The following is a description of a gene set: Mouse Gene Set: TABULA_MURIS_SENIS_HEART_AND_AORTA_SMOOTH_MUSCLE_CELL_AGEING from publication Tabula Muris Consortium (PMID 32669714) studied in species Mus musculus, and this is the list of marker genes: Pnrc1, Nr4a2, Btg1, Id3 (NCBI Gene Id 15903), Prnp (prion protein), S100a6, Ctsd, Eef1a1, Ttll7, Capg (NCBI Gene Id 12332), Cdkn1a, H2-D1, Gstm1, Rps28, Junb, Fos, Nr4a1, Pdlim1, Sncg, Fosb, Plac9, Zfp36, Rpl38, Fosl2, Rbm3, Higd1b, Dcn, Cebpb, Ddx5, Ppp1r15a, Ier3, Hes1, Rps29, Pde4b, Atf3, Ubc, Rpl31-ps12, Ier5, Aldh2, Jund, Jun, Cebpd, Rpl39, Rpl6, Gm13889, Nfkbiz, Ftl1, Gas5, Gstt1, Btg2, H2-Q4, Malat1, Hsp90aa1, Socs3, Rasl11a (NCBI Gene Id 68895)